Given this list of marker genes KPNA2, CAMKK2, CAMK2A, CAMK2D, CAMK2G, CAMK4, CAMK2B, CREB1, CAMKK1 (NCBI Gene Id 84254), CALM1, here is a description of the gene set: part of: Calmodulin induced events species: Homo sapiens The Ca2+-calmodulin-dependent protein kinase (CaM kinase) cascade includes three kinases: CaM-kinase kinase (CaMKK); and the CaM kinases CaMKI and CaMKIV, which are phosphorylated and activated by CaMKK. Members of this cascade respond to elevation of intracellular Ca2+ levels. CaMKK and CaMKIV localize both to the nucleus and to the cytoplasm, whereas CaMKI is only cytosolic. Nuclear CaMKIV regulates transcription through phosphorylation of several transcription factors, including CREB. In the cytoplasm, there is extensive cross-talk between CaMKK, CaMKIV and other signaling cascades, including those that involve the cAMP-dependent kinase (PKA), MAP kinases and protein kinase B (PKB/Akt). Reactome Pathway: CaMK IV-mediated phosphorylation of CREB